The following is a description of a gene set: Any process that modulates the frequency, rate or extent of skeletal muscle cell differentiation. studied in species Mus musculus Mouse Gene Set: GOBP_REGULATION_OF_SKELETAL_MUSCLE_CELL_DIFFERENTIATION, and this is the list of marker genes: Six4, Mir669a-3, Nr1d2, Tbx1, Ephb1, Mir669a-5, Myocd, Mef2c, Gpc1, Kat8, Six1, Akirin1, Ddx17, S100b, Mir669a-6, Mir669a-10, Rbm24, Klhl41, Hdac5, Mir669a-7, Mir675, Mir669a-8, Mstn, Mir669a-9, Mir669a-4, Mir669a-1, Hdac4, Bmal1, Ddx5, Uqcc2, Cyp26b1, Mir669a-2, Mcub, Rbfox1, Hdac9, Nln (neurolysin (metallopeptidase M3 family))